Given this list of marker genes ARX, GIPR, PROC, INHA, CAPSL, RAP1GAP2, OR51E1, KILH, CCK (NCBI Gene Id 885), TMED11P, CNGA3, KLB, PRODH2, ST8SIA5, GABRA1, MNX1-AS1, SST, ADH6, ONECUT3, NEUROD1, CDHR3, PAX6, SPTSSB, RGL3, LINC02197, C8A (NCBI Gene Id 731), KCNK17, PEX5L, LINC01765, TTC39A-AS1, ENSG00000229797 (NCBI Gene Id 124907890), SYT13, KCNK16, TTLL10, LINC00261, PAX4, LINC00616, PCSK1, FFAR4, GCG, LINC01811, UBE2QL1, GCH1, FEV, MAB21L4, GCK, HEPACAM2, CCDC162P, CACNA1A, BTBD17, SLC9A2 (NCBI Gene Id 6549), ERICH3, FOXA2, MLN, LINC00907, VWA5B2, CERKL, NKX2-2, RFX6, PYY, GIP, CALCR, GC, LMX1A, SSTR5, BAIAP3, MIR7-3HG, RAB3B, LMX1B, LINC02388, GLRA3, ENSG00000224090, SLC38A11, KCNH6, CEP126, MS4A8, LCN15, LINC01014, GHRL, DYNLRB2-AS1, PCSK1N, BHMT, TMEM132D, PNMT, REG4, RAB26, SSTR5-AS1, IL20RA, ASIC5, STXBP5L, SCG2, DNAH12, ENSG00000239482, CRYBA2, ENSG00000254718, ST18 (ST18 C2H2C-type zinc finger transcription factor), ADGRG4, GAD2, PAM, TPH1, PLCXD3, LINC01106, KIF19, TRPC7, TGM3, SNTG1, ROS1, SLC18A1, CHGA, PDX1, DRAIC (downregulated RNA in cancer, inhibitor of cell invasion and migration), SSTR2, LRP1B, here is a description of the gene set: studied in species Homo sapiens Marker genes curated from the annotated cluster as represented in the Descartes Human Gene Expression During Development database. from publication Cao J, O'Day DR, Pliner HA, Kingsley PD, Deng M, Daza RM, Zager MA, Aldinger KA, Blecher-Gonen R, Zhang F, Spielmann M, Palis J, Doherty D, Steemers FJ, Glass IA, Trapnell C, Shendure J (PMID 33184181) Human Gene Set: DESCARTES_FETAL_INTESTINE_CHROMAFFIN_CELLS The gene expression program underlying the specification of human cell types is of fundamental interest. The study authors generated human cell atlases of gene expression and chromatin accessibility in fetal tissues. For gene expression, the study authors applied three-level combinatorial indexing to >110 samples representing 15 organs, ultimately profiling ~4 million single cells. The study authors leveraged the literature and other atlases to identify and annotate hundreds of cell types and subtypes, both within and across tissues. Our analyses focused on organ-specific specializations of broadly distributed cell types (such as blood, endothelial, and epithelial), sites of fetal erythropoiesis (which notably included the adrenal gland), and integration with mouse developmental atlases (such as conserved specification of blood cells). These data represent a rich resource for the exploration of in vivo human gene expression in diverse tissues and cell types.